Given this list of marker genes CLCA1, ANXA4, RAB3D, SYCN, ZG16, VAMP2, DNASE1, DMBT1, TMED2, SLC30A2, SCAMP1, TMED10, STX3, GP2, PNLIPRP2, STXBP2, CUZD1 (NCBI Gene Id 50624), SLC9A4, VAMP8, RAB27B, here is a description of the gene set: Human Gene Set: GOCC_ZYMOGEN_GRANULE studied in species Homo sapiens A membrane-bounded, cytoplasmic secretory granule found in enzyme-secreting cells and visible by light microscopy. Contain zymogen, an inactive enzyme precursor, often of a digestive enzyme.